Given this list of marker genes FOXD1, TPM4, SULT1E1, ECH1, TNFAIP6, BCL6, CD44, F2RL2, ANXA4, SLC38A11, GLT8D2 (NCBI Gene Id 83468), ELL2, COL5A2, HBA1, L1TD1, FILIP1L, MFRP, IFI44, PTH1R, SLC6A12, RAB13, CDH11, CAV2, PLCL1, FN1, DYNLT3, MIR4435-2HG, RAPGEF3, GGTLC2, ACTA2, ANXA5, TXNIP, KCNJ8, SLC16A12, SORBS1, LPP-AS2, UBASH3B, BGN, MMP25, CPT1A, SVEP1, EGR2, DNM3OS, LAMB2, APOE, RGL1, CD81 (CD81 molecule), CRIP1, NOSTRIN, CSRNP1, STARD13 (NCBI Gene Id 90627), KLF6, PDZD2, EDNRA, SYNPO, PDE3A, ID3, DCBLD1, PAG1, ARHGAP26, FRMD8, TGFBI, PGGHG, ZIC1, COL6A1, COL1A2, FOXS1, GADD45B, SLC9A1, DNAJB4, LOXL2 (NCBI Gene Id 4017), AXL, CRTAP, SPARC, ITGB5, LZTS1, ANGPT2, TGFB3, SNHG12, RGS16, RSU1, CCN4, PTPRG, PAPSS2, KIRREL1, FBN1, IFITM2, TCIRG1, LUM, ASB9, LGALS3BP, ERF, CETP, PDGFRL, OLFML2A, CDC42EP5, EGR1, MIR198, PPARGC1B (PPARG coactivator 1 beta), LHFPL6, CD164, GAS6, SHC1, SEPTIN7, POMP, ZBTB2, LPAR6, SUCLG2, SYTL2, HEXIM1, F3, MAP2K3, SPTBN1, UNC5B, EML3, KLF9, TTYH2, DGKA, TNS2, LRRC17 (leucine rich repeat containing 17), RHBDL2, ATP1B2, CHMP1B, VSTM4, VCL, GALNT18, LMNA, SLC66A3, TNN, FSTL1, PARP14, GMFG, POLD4, MAFF, NID1, PIK3CD-AS2, ST3GAL5, FCHSD1, CALD1, CTDSP1, ZFP36L1, CCDC3, TULP2, NFE2L2, FLNA, SCN4B, PTPRM (protein tyrosine phosphatase receptor type M), CDC42EP2, CALU, CACNA1C, HBA2, SERINC5, ABCC9, CTSK, NAGA, ANKRD44, NQO1, RUNX3, DDIT3, FRMD6, ABCA1, MELTF, HEY2, RFTN1, PABPC4L, KCNE4, EPS8, ANTXR1, EPSTI1, EPB41L2, KLF3, MGLL, TBX2, PLAC9, NHERF2, RBMS1, CAVIN3, MMP11, PHLDA1, MSRB3, FES, HAAO, YBX3, ADGRA2, TSC22D4, DCN, MYADM, BTN3A3, UACA, MXRA5, THY1, CADM4, TFPI, SIDT1 (NCBI Gene Id 54847), SERPING1, MOCS1, OLFML1, GJA4, LYPD3, ADAM9, RERGL, NDUFA4L2, LATS2, SCPEP1, ARHGDIB, C1QTNF1, SSR3, STOML3, M6PR, PRKCD, SLC6A1, SNAP23, NRARP, PIP5K1B, MCAM, PIEZO2, GUCY1A1, PIK3CD, ELOVL1, CYSLTR1, GRM3, MUSTN1, LAMC1, PEAK1, LAMA2, COL21A1, NR2F2, CD4, HTR1A, MOGAT1, B2M, NCOA7, RBMS3, ITPRIPL2, COX4I2, NR4A1, GIPC3, GUCY1B1, ECM2, FARP1, ITGA8, KCNMB3, GJA5, PER1, CYTH3, NAB1, ANKRD37, CYP4X1, PLXDC1, FABP4, SH3PXD2A, RHOJ, MSN, CRISPLD2, FNDC3B (fibronectin type III domain containing 3B), PLSCR1, CDH6, STAT6, SLC4A1, HIGD1B, FOXL1, PLVAP, FAM13A, PTEN, OSMR (oncostatin M receptor), HSPA2 (NCBI Gene Id 3306), CMKLR1, IGFBP4, DNAJC15, PRKG1, MS4A8, CA2, PTGDR2 (NCBI Gene Id 9484), ADAP2, TNFAIP1, GDF15, RHOC, PLA2R1, PDE2A, LCP2, ADAMTS1, SNHG18, MAML2, FOXQ1, LDLRAP1, ANPEP, ARHGEF17, CD248, LAYN, CFH, ISYNA1, SOCS3, RAPGEF5 (NCBI Gene Id 9771), NFATC4, ACOT9, PYCARD-AS1, CA4 (carbonic anhydrase 4), PNRC1, CD163L1, HBEGF, ARHGAP24, MAGT1, RBPMS, HEYL, EFHD2, PIEZO1, TUBB6, TBX18, CLDN7, CSAG1, GEM, ITGB1, GRK3, IFITM3, EHD2, ISCA1, CD63, NID2, LMOD3, CHST2, ITGA4, ABHD2, WASF2, GNG11, C11orf96, SLC2A14, EML2-AS1, HES4, TMBIM1, FHL5, APOLD1, ITM2C, PLAT, FMNL3, GLS, VAMP5, COL4A2, SPARCL1, SPON2 (spondin 2), WIPI1, ANXA2, EPHB4, ITIH5, SNAI2, FKBP1A, CCN1, SLC25A5, CCL2, SYCP2, RBMS2, LAMC3, HSPB8, KRT17, TRIM38, TMC4, ADA, ITGA1, P2RY14, PKIG, CHSY3, ADAMTS4, ANXA6, ABCA9, SERINC3, EMP2 (epithelial membrane protein 2, NCBI Gene Id 2013), ATF3, EGR3, CYSTM1, MGP, TIMP1, ITPRIP, TLE1, GPC1, MICOS10-NBL1, SNRK, STOM, CARMN, TRIM22, CASTOR1, ALX4, DBH, SNX18, RASL12, ARHGEF4, UBA7, SDCBP, DCLK3, ILK, PALD1, SH2D3C, JUN, GIMAP2, REEP3, COL5A3, SYPL1, TMEM74B (NCBI Gene Id 55321), NAALADL1, HOPX, GGT5, INS-IGF2, GLRX, SERPINB6 (serpin family B member 6), PXDN, LBH (NCBI Gene Id 81606), RRAS, TSPAN7, GBGT1 (NCBI Gene Id 26301), PLSCR4, RCSD1, PZP, ARRDC2, HCST, TRPV2, HADHB, ALDH9A1, PMP22, PCDH18, SEPTIN4, F2R, PELO, ZIC4 (Zic family member 4), AMOTL1, GUCY1A2, ING1, TIMP2, L3HYPDH, TACC1, PPP1R12A (protein phosphatase 1 regulatory subunit 12A), TGFBR2, ATP1B3, ACTN1, ARAP3, MYL9, SPRY1, EHBP1L1, SLCO1C1, ITGAV, TSC22D3, PXDC1, FRZB, ZYX, PRMT8, PTGS2, FMO1, RASGRP2, GSTK1, SMAGP, CD9, POLR1F, AXIN2, PDLIM1, LTBR, PARVA, B4GALT3, STING1, PLOD1, PLEKHG2, KLHL15, CDKN1A, TMEM35B, IRF1, ASAH1, ROBO3, HBG1, IFITM1, LGALS1, PRKCB, FOXC1, C9orf153, EFCAB5, COL18A1, STEAP1B, MYO1C, IFI35 (NCBI Gene Id 3430), TAGLN2, SERTAD1, RNF135, SPRY4, LINGO1, PRELP, EFCAB14, AP2S1, PLEKHH2, DENND2B, PIP4P2, STARD8, COL3A1, TJP1, DACT3, ARID5B, FERMT2, EPHX1, C2CD2L, FOXF2, PTGR1, PPFIBP1, CD19, DBNDD2, GPR4, NODAL, ENPEP, MPZ, ZC3HAV1, CASP4, HBG2, KLF1, PRKAR1A, SERF1A, RCAN1, A2M, AVPR1A, PXK, SPATS2L (NCBI Gene Id 26010, spermatogenesis associated serine rich 2 like), JAG1, TBC1D2B, LRRC32, SASH1, TPM2, ZFP36, KRT5, AKAP12, MAP3K5, SLC38A2, TWIST1, OPCML, DGKH, SEPTIN8, MAP1LC3A, PGF, FAR2, DSP, GRN (NCBI Gene Id 2896), MYL12B, TLN1, TNFRSF1A, NIBAN1, JAK1, CALCRL, CISD1, APOL6, ZBTB38, VAMP8 (NCBI Gene Id 8673), KCNS3, FGD5, MEF2D, DACT1, ADAMTS18, ADCY4, PDE7B, ARHGEF12, GLA, DUSP5, CPED1, MFGE8, C16orf89, PHLDB3, MAGED2, LIMA1, GGT1, SH2B3, SCAMP2, UGP2, FCGRT, ZIC2, TMEM19, COL9A1, ARHGEF6, CCDC17, BCL3, SLC12A2, GPNMB, ZEB1, HES1, MYLK, SPECC1, TESC, CISH, NOTCH3, NR4A3, PLCE1, LEPR, TNFAIP3, FKBP5, PTN, EVA1B, RBMS3-AS3, SLC2A2, VSIG2, EFEMP2, CFHR1, TBXA2R, PFN1, WWTR1, IL17RC, LRP1, AFAP1L2, CCDC8, SYTL4, COLEC11, CCM2L, MRC2, ARHGAP15, IER2, LPP, CSPG4, MIR22HG, PRR16, ARHGAP29, STAT3, TNS3, ARHGAP1, EMCN, IL1R1, PPIB, SERPINH1, FZD1, HSPB1, HRC, ADORA2B, SH3KBP1, ARHGAP6, KCP, SLC35A1, ZBTB46, GPR21, KCNMB1 (potassium calcium-activated channel subfamily M regulatory beta subunit 1), CCL8, WDFY4, PLA2G4C, SPRED1, PCOLCE, RGS5, COX7A1, JAML, ISG15, CYBA, IGFBP7, IQGAP1, CLEC11A, GSN, APOBEC3C (apolipoprotein B mRNA editing enzyme catalytic subunit 3C), TSPAN12, C1S, CCT8L1P, EPHA2, CMTM6, PTPRK, MYC, TENT5A, LRIG1, COBLL1, RUNX1, MYOF, RNF213, UCKL1-AS1, NOTCH2, OAZ2, LAMA4, SLC8A1, PDE8B (NCBI Gene Id 8622), MYO1B, SEPTIN6, PPP1R14A, ITGA11 (integrin subunit alpha 11), DOCK6, CDK7, NR3C1, CPQ, TEAD4, TAPBPL, CACNB4, NCK2, EPAS1, ADAM12, SEPTIN11, ADGRF5, GJC1, PDGFRB, EMILIN1, PDLIM2, KMT2E-AS1, TMOD3, VAMP3, BCHE, NUDT4, GABRE, TGFB1, MYH9, CHCHD1, SRPX, HTRA3, SNHG5, ITPKB, SYNM, PDE5A, RAPGEF4, SVIL, ATP1A2, PDE8A, GAB1, HTR1F, FAM43B, SLC2A3, GPX8, HIC1, OLFML3, CAMK2D, MEF2C, TNFRSF21, BCAP29, CREM, GPER1, SMTN, TRPC6, NECTIN2, EVA1C, NKX3-2, FAM162B, FRMD4B, CEBPB-AS1, AGRN, AGAP2-AS1, OSTF1, ECE1, CAST, PABPC1, PLTP, RARG, DOCK1, ZNF73P (zinc finger protein 73, pseudogene), LAPTM4A, MYL12A, KCNE3, LIMS1, ETS1 (NCBI Gene Id 2113), IFI27L2, LRRC55, PLS3, HBB, KANK1, NHERF1, KCNK3, SEMA5A, COLEC12, CEBPD, PLAUR, PMEPA1, TES, LAG3, MYOM2, TAGLN, KANK2, SHISA3, PRDX4, ANGPTL4 (NCBI Gene Id 93954), MAP3K20 (mitogen-activated protein kinase kinase kinase 20), MT2A, EPB41L1, EBF1, ZNF716, AAMDC, DRAM1, PDE4C, HTATIP2, ENTPD1, PAMR1, PID1, WDR1, ATP8B1, TNS1, PPIC (NCBI Gene Id 5480), SGCE, PRX, GPRC5C, SLC12A7, MTUS1, ARHGAP42, FOSB, GP1BB, S1PR3 (sphingosine-1-phosphate receptor 3), RRAD, FOS, COL4A1, LSMEM1, LAMB1, CXCL2, SIK1, ABHD17A, JUNB, ADGRD1, RFXANK, GNG12, TBX15, STAT4, DAAM2, here is a description of the gene set: Cell types are named using anatomical and functional mnemonics prefixed by 'm' or'h' to indicate mouse and human respectively: OMTN, oculomotor and trochlear nucleus; Sert, serotonergic; NbM, medial neuroblast; NbDA, neuroblast dopaminergic; DA0-2, dopaminergic neurons; RN, red nucleus; Gaba1-2, GABAergic neurons; mNbL1-2, lateral neuroblasts; NbML1-5, mediolateral neuroblasts; NProg, neuronal progenitor; Prog, progenitor medial floorplate (FPM), lateral floorplate (FPL), midline (M), basal plate (BP); Rgl1-3, radial glia-like cells; Mgl, microglia; Endo, endothelial cells; Peric, pericytes; Epend, ependymal; OPC, oligodendrocyte precursor cells. Human Gene Set: MANNO_MIDBRAIN_NEUROTYPES_HPERIC from publication La Manno G, Gyllborg D, Codeluppi S, Nishimura K, Salto C, Zeisel A, Borm LE, Stott SRW, Toledo EM, Villaescusa JC, Lönnerberg P, Ryge J, Barker RA, Arenas E, Linnarsson S (PMID 27716510) studied in species Homo sapiens